The following is a description of a gene set: Reactome Pathway: Activated NTRK3 signals through RAS Upon activation by NTF3 (NT-3), the receptor tyrosine kinase NTRK3 (TRKC) triggers RAS signaling through adaptor proteins SHC1 and GRB2. ERK activation downstream of NTRK3 may increase cell motility through WAVE. The mechanism is not known. part of: Signaling by NTRK3 (TRKC) species: Homo sapiens, and this is the list of marker genes: NTRK3, NTF3, NRAS (NCBI Gene Id 4893), SOS1, GRB2, KRAS, HRAS, SHC1